Given this list of marker genes Arf6, Nfkbiz, Tmem258, Lims1, Prkaa1, Ppargc1a, E2f2, Jak2, Nkx2-6, Gsk3b, Wfs1, Igf1, Hmox1, Six3, Selplg, Hand2, Btc, Fas, Hdac3, Dnmt3a, Exoc5, Adar, Zfp36l1, Cflar, Jag2, Pgr, Ttpa, Mtor, Bad, Pias4, Pla2r1, Krt18, Umodl1, Casp6, Pkhd1, Casp3, Gcm2, Abl1, Wnt11, Mtch2, Agap2, Serpinb13, Sav1, Itgb3bp, Ednra, Pdx1, Gsn, Nkx2-5, Isl1, Sfrp4, Nupr1, Krt8 (keratin 8), Tcf7l2, Cast, E2f1, Bcl2, Carm1, Yap1, Zfp36, Trim32, Sort1, Stk3, Neurod1, Lef1, Tia1, Srsf6, Apc (NCBI Gene Id 11789), Igf1r, Capn10, Usp53, Atg7, Pik3cg, Mst1, Tgfbr2, Ppara, Myc, Spop, Eif2s1, Ryr2, Stk4, Atoh1, Bok, Fgf4, Prkaa2, Cdkn1b, Arrb2, Kcnn4, Casp8, Atf7, Ngf, Bid, Casp9, Pla2g1b, Bax, Npc1, Ager, Mdk, Psmd9, Mapk8 (mitogen-activated protein kinase 8), Bcl2l1, Esr1, Alms1, Rb1, Tmf1, Atf2, Naip1, Anxa2, here is a description of the gene set: Mouse Gene Set: GOBP_EPITHELIAL_CELL_APOPTOTIC_PROCESS studied in species Mus musculus Any apoptotic process in an epithelial cell.